The following is a description of a gene set: In mammalian cells, many antioxidant defence systems exist which protect cells from subsequent exposure to oxidant stresses. One antioxidant is glutathione (GSH), a tripeptide present in virtually all cells that regulates the intracellular redox state and protects cells from oxidative injury. It is metabolised via the gamma-glutamyl cycle, which is catalysed by six enzymes. In man, hereditary deficiencies have been found in five of the six enzymes. Gamma-glutamylcysteine ligase (GCL) catalyses the first and rate-limiting step in GSH biosynthesis. GCL is a heterodimer of a catalytic heavy chain (GCLC) and a regulatory light chain (GCLM). Defects in the catalytic GCLC can cause hemolytic anemia due to gamma-glutamylcysteine synthetase deficiency (HAGGSD; MIM:230450), a disease characterised by hemolytic anemia, glutathione deficiency, myopathy, late-onset spinocerebellar degeneration, and peripheral neuropathy (Ristoff & Larsson 2007, Aoyama & Nakaki 2013). part of: Metabolic disorders of biological oxidation enzymes Reactome Pathway: Defective GCLC causes HAGGSD studied in species Homo sapiens, and this is the list of marker genes: GCLM, GCLC